The following is a description of a gene set: Human Gene Set: HP_HYPOPLASIA_OF_THE_OLFACTORY_BULB species: Homo sapiens Hypoplasia of the olfactory bulb Underdevelopment of the olfactory bulb., and this is the list of marker genes: SMCHD1, ZSWIM6, SEMA3A, GSX2, FOXP2, TUBB3, POU3F3